The following is a description of a gene set: Human Gene Set: HP_SKIN_VESICLE species: Homo sapiens Skin vesicle A circumscribed, fluid-containing, epidermal elevation generally considered less than 10mm in diameter at the widest point., and this is the list of marker genes: ATP2A2, MEFV, TINF2, WRAP53, SLC35C1, PSENEN, CTC1, TERT, KRT5, RTEL1, STAT3, TERC (NCBI Gene Id 7012), NOP10 (NCBI Gene Id 55505), PLEC (NCBI Gene Id 5339), POGLUT1, COL7A1 (NCBI Gene Id 1294), NPM1, DSC3, PTPN6, NHP2, USB1, PPOX, POFUT1, ATP2C1, TYMS, DKC1, PARN